Given this list of marker genes RARS2, FUOM, EMC6, HOXB9, HS6ST1, SH3BGRL3, GALT, CCT7, MKNK2, ZNF865 (NCBI Gene Id 100507290), SLC39A11, DLG1, C6orf89, MRAS, PHF5A, TNFRSF18, MRTO4, TUBGCP2, YARS1, NOL7, PALD1, NOA1, NDUFA10, NOL6, NCALD, ERCC5, SELENON (selenoprotein N), RNF126, PLPP2, COL17A1, PRG2, PYGB, MRPL51, MDP1, PMFBP1, MIEN1, CPA1, GJC2, MPHOSPH9, BABAM1 (BRISC and BRCA1 A complex member 1), SAE1, PGP, PRKACA, ZNF532, PUS7, IZUMO1R, PPP4C, DDX18, RPS15A, VPS37A, GRWD1, MRPS24, UXT, SLC47A1, SDHAF2, CCDC115, IQGAP3, KLF10, PES1, LIMK1, CST11, SYNPO, IFRD2 (interferon related developmental regulator 2), TLE6, NDUFAF1, NABP2, PPP1R14B, HMBS, CHST10, CATSPER1, MED30, ADAMTS7, ALDH18A1, MRPL3, FOXO1 (NCBI Gene Id 2308), OTC, NDUFC2, TSGA13, MVK, PABPC4, PTPN18, PUM3, CTDSP1, ACY1, KRT2, CHCHD6, NDUFS2, SLC50A1, CLNS1A, KRTCAP2, CPSF1, DAD1, WDR45, EBP, ADK, TIGD5, CELSR2, SEC16A, XPA, ENTREP3, TRMT1, USP10, SLC18A1, PDXK, SNRNP70, ANP32B, LBX2, NEFH, SDHAF1, SFXN3, SC5D, UTP11, CYP21A1P, PIP4K2A, BUB1, FANCE, NR4A1, ARRB1, ZNF703, TMEM50B, FASN, POP7 (NCBI Gene Id 82671), STRBP, GPS1, NME2, RBX1, VAV3, FAM162A, PTH1R, LTBR, STARD4, HNRNPU, NF2, C1QL1, TAF10, CLEC6A, GSTK1, SCRG1, SELENBP1, FABP9, CDC25C, TTC4, POLR1D, ARHGDIB, PTPRS, MTAP, CEBPZOS, CD93, RAP1A, SIDT2 (SID1 transmembrane family member 2), NCBP1, SLC25A4, AUH, GNPDA1, ADAM15, CCDC28A, CCR2, KLHDC4, PADI2, TIMP1, GSTM3, UFSP2, TFRC, PC, STOML2, EML5, FTO, G6PC1, DNAJC10, PHPT1, NDUFAF7, XBP1, MRPL20, SLC17A2, SPTBN1, ACOX1, BDH1, LSM14A, TMEM199, GTF2H4, ACO2, POGLUT2, NSMCE4A, MRPS15, ICOS (NCBI Gene Id 29851), IRAG2, ROMO1, NHP2, PCSK5, CRTAP, MYL9, EMC2, ERLIN1, MSL3, ADIG, TAF11, C8G, LHX1, AP2S1, ESRRA, here is a description of the gene set: species: Homo sapiens Human Gene Set: GSE17721_0.5H_VS_12H_POLYIC_BMDC_UP from publication Amit I, Garber M, Chevrier N, Leite AP, Donner Y, Eisenhaure T, Guttman M, Grenier JK, Li W, Zuk O, Schubert LA, Birditt B, Shay T, Goren A, Zhang X, Smith Z, Deering R, McDonald RC, Cabili M, Bernstein BE, Rinn JL, Meissner A, Root DE, Hacohen N, Regev A (PMID 19729616) mouse primary BMDCs were stimulated with tlr ligands and gene expression changes were profiled on Affymetrix arrays Genes up-regulated in comparison of dendritic cells (DC) stimulated with poly(I:C) (TLR3 agonist) at 0.5 h versus those stimulated at 4 h.